The following is a description of a gene set: Mouse Gene Set: DESCARTES_ORGANOGENESIS_DEFINITIVE_ERYTHROID_LINEAGE Mouse Organogenesis Cell Atlas (MOCA) DE_gene_main_cluster.csv, fold.change>=1.5, qval<0.05, pval<0.05 from publication Cao J, Spielmann M, Qiu X, Huang X, Ibrahim DM, Hill AJ, Zhang F, Mundlos S, Christiansen L, Steemers FJ, Trapnell C, Shendure J (PMID 30787437) studied in species Mus musculus, and this is the list of marker genes: Tspo2, St3gal4, Slc1a5, Dennd4a, Gm37915, Tspan8, Nxpe2, Or10d1, Dnah8, H2ac22, Ccdc137, Slc26a1, F930017D23Rik, Gdf3, 9430081H08Rik, Specc1 (sperm antigen with calponin homology and coiled-coil domains 1), 6720464F23Rik, Them6 (NCBI Gene Id 78051), 1700086O06Rik, Nudt12, Fn3k, Rpl35, Dedd2, Gm38825, Ampd3, Sh2d4a (NCBI Gene Id 72281), Zdhhc24, Aoc2, Tonsl, Car1, Slc66a2, 4930581F22Rik, Trmo, Tbc1d24, Pml, Apol8, Lmo2, 6030458C11Rik, Mns1, Septin8, Elmo3, 4931422A03Rik, Abcb4, Ces2g, Tnfaip2, Btnl10, Ccnb1ip1, Wrn, 2310040G07Rik, Cdc6, E430021H15Rik, D030056L22Rik